The following is a description of a gene set: Genes predicted to be targets of miRBase v22 microRNA hsa-miR-5009-3p in miRDB v6.0 with MirTarget v4 prediction scores > 80 (high confidence targets). from publication Chen Y, Wang X (PMID 31504780) species: Homo sapiens Human Gene Set: MIR5009_3P, and this is the list of marker genes: RNF115 (NCBI Gene Id 27246), PGM2L1, PTN, STEEP1, TMEM64, CTNNA3, C3orf70, DSC2, UBR2, E2F7, DNM3, TNFRSF19, ANKRD20A1, RPS6KB1, METTL14, MSN, TPD52, ANKRD20A2P, GRM1, BPNT1, ARHGEF26, ACOT13, KRT10-AS1, PPM1L, ZNF800, ASTN2, ZFAND3, ESYT3, NADK2, MREG, FRS2, MKLN1, PRKDC, KIF3C, STEAP2, CDK1, CLMN, ANKRD20A4P, ERC2, ATRX, GGACT, AHSA2P, MTERF3, GPC2, BCDIN3D, PATZ1, MINDY2, KHDRBS1 (NCBI Gene Id 10657), MOB3B, UCP3, CEP72, LRRC58, ZNF180, BTBD1, BTBD10, RPS3, CHIC1, TAB2, PABPC4L, DNHD1, PIKFYVE, ZNF540, TMEM267, SAP18, SCD5, MS4A7, CNOT2, TMEM207 (NCBI Gene Id 131920), LPGAT1, AMIGO2, PBRM1, EPHA7, AEBP2, PEX13, NUBPL, ARL8B, LATS2, PTBP2, SPIDR, ETNK1, ZNF333, BRWD3, FZD1, AGO1, ST8SIA1, STIM2, SLC16A7, NUDT13, TBC1D4, NEUROD4, ZNF518B, EFCAB5, LIFR, C7orf57, GLRB, JPH1, CYRIB, RAB40B, NEMF, RBMS1, FNDC5, NEDD9, BUB1B, PPBP, TRIM5, TRIM23, MAP9, CDH7 (NCBI Gene Id 1005), SESN3, PJA2, CDC5L, FOXO1, SLCO1A2, ANKRD20A3P, ZBTB1, SYT14, SAMTOR, MKKS, ABCA10, EFR3A, RPRD1B (NCBI Gene Id 58537), DGKE, MPPED2, ATRN, MTMR4, SLC16A1, SMNDC1, CRMP1, C5orf15, NSL1, TMEM65, DMRTA2, USP32, WWC1, GRIA2, DSC1, GLCE, PLCXD3, CECR2, PLOD2, LYSMD2, PHC3, OGFRL1 (opioid growth factor receptor like 1), ASPH, CDH19, GATM, ZNF740, NFAT5, DKK2, CAND1, MDFIC, PARM1, TRPC5OS, LYSMD3, CDKL2, RTKN2, PDX1, C1orf21, SREK1IP1, PRTG, NDFIP2 (NCBI Gene Id 54602), ADARB2, TRIM6, GFPT1 (glutamine--fructose-6-phosphate transaminase 1), BOLL, NDUFAF6, ACBD5, TMEM169, SERPINI1, SLC1A2, DCTN4, UBE2K